Given this list of marker genes CCDC124, HERPUD2, JARID2, DIO1, CRHR2, CISD3, SH3BP2, PRDM4, HSPE1, KCMF1, TMEM223, CTSW, SATB1, CSRNP1, SRXN1, MARCKSL1, TAGLN3, TUBB2A, DUSP8, SLC66A2, RAB2B, GALNS, QPCT, FNTA, H2AJ, GKAP1, HSPH1 (heat shock protein family H (Hsp110) member 1), SLC5A11, HBG2, SRF, CCDC71L, DOC2B, PTPN1, USP15, MAP1LC3A, ERF, PROSER1, COPG1, ARL3, MLLT11, TBCK, SETD1B, AAMDC, FOSB, STPG4, MCTS1, NR4A1, NUDT5, ARHGAP21, DUOXA1 (dual oxidase maturation factor 1), ZNF703, VKORC1, LAMA3, TLR9, KLHL28 (NCBI Gene Id 54813), CD207, GAS8, UBXN8, TMEM132D (transmembrane protein 132D), CELA3B, RBBP5, TOX2, LSAMP, FIBCD1, NFKBID, CHEK1, RDH10, ITGB1BP1, FOXN1, PSMD2, NPAS1, RBM33, HSCB, CALR3, SARAF, IL17RA, PHOSPHO1, AREG, CISH, TDP1, GATA2, CHORDC1, LGALSL, CHKA, EIF2B2, TP53BP2, NRAS, UBP1, ADGRB2, C12orf56, SVIP, TMEM200A, AZI2, CYB5RL (NCBI Gene Id 606495), ASB15, ADI1, UBL3, CYP24A1, FGD6, SLC5A2, UBE2F, DNASE2B, DTNB, HSPD1, MAP1LC3B, PDLIM2, SLCO1B3, LINC01160, ABL2, HPS1, VWA8, PLPPR1, HIKESHI, POU5F1, DDX6, DCTD, JSRP1, GFUS, HSPA2, KANSL1, TRPV6, ARL4D, TAT, PITHD1, UBE2G2, CLK3, ERAS, RALYL, PGF, SERF1A, EVC, KIF9, IRX5, XRCC5, TOB2, LEF1, RYR2, DUSP16, JUNB, GPNMB, MRPL20, MARVELD3, OGA, HBS1L, DARS1, EGR1, PLEKHH2, ARL5B, SLC13A4, FLACC1, PIGO, PCNP, JAM2, CELF6, EXOC5 (NCBI Gene Id 29024), SNAPC5, CHRD, ZNF623, TNFRSF25, GLIS1, PINK1, GPR26, GNAZ, BCL6, NDUFAB1, GEM, FGF3, ZFAND2A (zinc finger AN1-type containing 2A), VLDLR, ARAP2, GTSF1, MRPL42, DPH3, PIM1, GCDH, MANBAL, ERG, TCFL5, IRX3, WDR83OS, JADE3, DOK3, RTCA, FGF21, SDHA, PWWP2B, MTMR1, ABCB9, RBM12, ANAPC15 (anaphase promoting complex subunit 15), HTATIP2, DUSP2, GADD45B, CSTA, KRT32, ZNF469, MARCHF4, CFAP53, CYP11B2, SRD5A2, here is a description of the gene set: Removal of the transcription factor SAP1a member of the Ternary Complex Factor (TCF) group of transcription factors which in conjunction with Serum Response Factor (SRF) has been shown to have a profound effect on positive selection in the thymus. When another TCF Elk1 is knocked out in mice there is no effect on positive selection unless it is on a Sap1a KO background where the phenotype is very severe. We have stimulated isolated double positive T cells (DPs) with anti-CD3 to mimic positive selection and compared basal and stimulated transcription across the four genotypes to discover the downstream targets of Sap1a involved in positive selection. from publication Costello P, Nicolas R, Willoughby J, Wasylyk B, Nordheim A, Treisman R (PMID 20554967) species: Homo sapiens Human Gene Set: GSE21546_WT_VS_ELK1_KO_ANTI_CD3_STIM_DP_THYMOCYTES_UP Genes up-regulated in double positive thymocytes stimulated by anti-CD3: wildtype versus ELK1 knockout.